Given this list of marker genes PROX1, NRG3, TBX2 (T-box transcription factor 2), HDAC1, SIX1, FOXI3, SIX4, HDAC2, NRP1, GNAS, EDA, DKK4, FRS2, CTNNB1, TBX3, here is a description of the gene set: studied in species Homo sapiens The progression of an ectodermal placode over time from its initial formation until its mature state. An ectodermal placode is a thickening of the ectoderm that is the primordium of many structures derived from the ectoderm. Human Gene Set: GOBP_ECTODERMAL_PLACODE_DEVELOPMENT